Given this list of marker genes Mphosph8, Msl1, Mfn1, Masp1, Utp4, Prox1, Ugt2b5, Abcg5, Secisbp2, Sorbs2, Ghr, Tbcel, AW209491 (expressed sequence AW209491), Dleu2, Ell2, H2-T13, Tmem39a, Atp6v0a2, Vcpip1, Ar (androgen receptor), Usf2, Tmem98, Luc7l2, Paxx, Pex19, Gstm6, Cherp, Gtpbp4, C8g, Eif4a3, Cryl1, Nek4, 4632415L05Rik, Gpr61, Reln, P2ry1, Ybx3, Tsr1, 9030622O22Rik, Cd109, Macroh2a1, Mylk, Ptgds, Sucnr1, Cmklr1, here is a description of the gene set: Mouse Gene Set: CHANGOLKAR_H2AFY_TARGETS_DN macroH2A histone variants have been implicated to function in gene silencing by several studies, including ones showing a preferential association of macroH2A on the inactive X chromosome. To examine macroH2A function in vivo, we knocked out macroH2A1. macroH2A1 knockout mice are viable and fertile. A broad screen of liver gene expression showed no evidence of defects in X inactivation but did identify genes that have increased expression levels in macroH2A1 knockouts. macroH2A1-containing nucleosomes are enriched on the coding and/or upstream regions of these genes, suggesting that their increased expression levels are a direct effect of the absence of macroH2A1. The concentrations of macroH2A1 nucleosomes on these genes are low in the livers of newborn mice, and the macroH2A1 knockout had little effect on the expression levels of these genes in newborn liver. Our results indicate that an increase in liver macroH2A1 during the transition from newborn to young-adult status contributes to a decrease in the expression levels of these genes. These genes cluster in the area of lipid metabolism, and we observed metabolic effects in macroH2A1 knockouts. Our results indicate that the function of macroH2A1 histones is not restricted to gene silencing but also involves fine tuning the expression of specific genes. Genes down-regulated in liver tissue upon knockout of H2AFY. species: Mus musculus from publication Changolkar LN, Costanzi C, Leu NA, Chen D, McLaughlin KJ, Pehrson JR (PMID 17242180)